Given this list of marker genes TIMP3, EGFR, CTNNB1, ZFAND6, SPP1, COL4A3 (NCBI Gene Id 200750), FN1 (NCBI Gene Id 2335), TGFBI, SQSTM1, CHI3L1, DYNC1I1, TFRC, TRIM24, CRYGS, GPNMB, ANXA2, NPC2, EDNRB, POLR2C, CSNK1A1, BHLHE40, PLIN2, TXNRD1, PGK1, PRRX1, FMOD, A2M, SLC30A9, here is a description of the gene set: Human Gene Set: COLIN_PILOCYTIC_ASTROCYTOMA_VS_GLIOBLASTOMA_DN from publication Colin C, Baeza N, Bartoli C, Fina F, Eudes N, Nanni I, Martin PM, Ouafik L, Figarella-Branger D (PMID 16314830) Genes down-regulated in pilocytic astrocytoma compared to glioblastoma samples. studied in species Homo sapiens Glioblastoma (GBM) is a highly malignant glioma, which has the propensity to infiltrate throughout the brain in contrast to pilocytic astrocytoma (PA) of the posterior fossa, which does not spread and can be cured by surgery. We have used Suppression Subtractive Hybridization to define markers that better delineate the molecular basis of brain invasion and distinguish these tumor groups. We have identified genes expressed in PA versus GBM and genes expressed in GBM versus PA. Subsequent analysis identified a subset of 20 transcripts showing a common differential expression pattern for the two groups. GBM differs from PA by the expression of five genes involved in invasion and angiogenesis: fibronectin, osteopontin, chitinase-3-like-1 (YKL-40), keratoepithelin and fibromodulin. PA differs from GBM by the expression of genes related to metabolism (apolipoprotein D), proteolysis (protease-serine-11), receptor and signal transduction (PLEKHB1 for Pleckstrin-Homology-domain-containing-protein-family-B-member-1), transcription/translation (eukaryotic-translation-elongation-factor-1-alpha1) processes and cell adhesion (SPOCK1 for SPARC/Osteonectin-CWCV-kazal-like-domains-proteoglycan). The expression of these genes was confirmed by real-time quantitative RT-PCR and immunohistochemistry. This study highlights the crucial role of brain invasion in GBM and identifies specific molecules involved in this process. In addition, it offers a restricted list of markers that accurately distinguish PA from GBM.